Given this list of marker genes CXCR1, FABP5P14, ABCA12, MIR6810, ZNF142, RPL37A, RNU6-642P (NCBI Gene Id 106481384), CTDSP1, TMEM198, MIR375, RNA5SP120, RPL37A-DT, FN1-DT, DNPEP-AS1, NHEJ1, MIR26B, ASIC4, FEV, ENSAP3, ENSG00000225166, SNHG31, RNF25, RN7SKP43, CDK5R2, RN7SKP38, INHA, ARPC2, TESHL, ENSG00000288898, VWC2L-IT1, SLC11A1, CXCR2, VIL1, CDK5R2-AS1, SNORA70I, RESP18, LINC00608, RPL7L1P9, LINC02832, USP37, SMARCAL1-AS1, CATIP-AS2, RPL31P14, RETREG2, RPL23AP31, PNKD, LINC00607, LINC01614, MARCHF4, PSMB3P2, PRKAG3, AAMP, FN1, ANKZF1, IGFBP2, ENSG00000290060, MREG, TNP1, GPBAR1, SPEG, ZFAND2B, SLC4A3, CYP27A1, ENSG00000233581, CRYBA2, WNT10A, TNS1-AS1, CXCR2P1, CATIP-AS1, MIR3132, MIR153-1, MIR9500, DNAJB6P3, PECR, XRCC5, MIR6809, MIR4268, TMEM169, DIRC3 (NCBI Gene Id 730949), RNU6-136P, TNS1, TUBA4B, STK11IP, ENSG00000308119 (novel transcript), ENSG00000231597, RPL23P4, ATG9A, DNPEP, TUBA4A, ASIC4-AS1, RUFY4, BARD1, TMBIM1, DES, DNAJB2, ABCB6, CNPPD1, SMARCAL1, HMGB1P9, RN7SKP213, STK36, IHH (Indian hedgehog signaling molecule), ATIC, PTPRN, WNT6, CNOT9, MIR3131, POLHP1, GLB1L, CATIP, PLCD4, STK16, LINC01280, LINC01963, LINC02862, ENSG00000224090 (NCBI Gene Id 100129175), RN7SL764P, CHPF, SPEGNB, BCS1L, GMPPA, KRT8P30, RPL19P5, CFAP65, RPL10P6, MIR6513, IGFBP5, SLC23A3, LINC01803, OBSL1, TTLL4, here is a description of the gene set: species: Homo sapiens Human Gene Set: chr2q35